The following is a description of a gene set: Mouse Gene Set: GOCC_EXOCYST A protein complex peripherally associated with the plasma membrane that determines where vesicles dock and fuse. At least eight complex components are conserved between yeast and mammals. species: Mus musculus, and this is the list of marker genes: Rab10, Exoc2, Exoc3, Exoc1, Exoc7, Tnfaip2, Exoc5, Grip1, Exoc3l2, Septin2, Exoc3l, Exoc4, Exoc3l4, Exoc8, Myrip, Washc1, Exoc6, Exoc6b (exocyst complex component 6B), Sh3bp1 (NCBI Gene Id 20401)